Given this list of marker genes MYOG, NKX2-6 (NK2 homeobox 6), ATXN2, LIF, TXNIP, SRSF10, DHX40, COL4A2 (collagen type IV alpha 2 chain), PSMD3 (NCBI Gene Id 94019), TEP1, ZC2HC1C, PBX1, CTSG, CETN1 (centrin 1), FPR2, ATP7B, SEMA5B, POLD4, DNASE1L2, PCSK4, FMO1, SFTPC, SPARC, SLC50A1, HSP90AB1, MYL4, here is a description of the gene set: species: Mus musculus from publication Bystrykh L, Weersing E, Dontje B, Sutton S, Pletcher MT, Wiltshire T, Su AI, Vellenga E, Wang J, Manly KF, Lu L, Chesler EJ, Alberts R, Jansen RC, Williams RW, Cooke MP, de Haan G (PMID 15711547) We combined large-scale mRNA expression analysis and gene mapping to identify genes and loci that control hematopoietic stem cell (HSC) function. We measured mRNA expression levels in purified HSCs isolated from a panel of densely genotyped recombinant inbred mouse strains. We mapped quantitative trait loci (QTLs) associated with variation in expression of thousands of transcripts. By comparing the physical transcript position with the location of the controlling QTL, we identified polymorphic cis-acting stem cell genes. We also identified multiple trans-acting control loci that modify expression of large numbers of genes. These groups of coregulated transcripts identify pathways that specify variation in stem cells. We illustrate this concept with the identification of candidate genes involved with HSC turnover. We compared expression QTLs in HSCs and brain from the same mice and identified both shared and tissue-specific QTLs. Our data are accessible through WebQTL, a web-based interface that allows custom genetic linkage analysis and identification of coregulated transcripts. Human Gene Set: BYSTRYKH_HEMATOPOIESIS_STEM_CELL_SCP2_QTL_TRANS Genes trans-regulated by the hematopoietic stem cell (HSC) proliferation QTL (quantitative trait locus) Scp2.